Given this list of marker genes Atp8b4, Slc35d3, Vmp1, Atp11c, Slc25a24, Slc25a47, Atp10b, Vapa, Abcc6, Calhm4, Slc35a5, Slc35a3, Slc35a2, Prelid1, Xkr4, Apoa5, Calhm6, Pitpnb, Lrrc8b, Slc33a1, Lrrc8d, Slc17a9, Slc35c1 (solute carrier family 35, member C1), Serinc3, Etnppl, Ldlr, Slc66a2, Triap1, Slc35d2, Prelid3a (PRELI domain containing 3A), Dbi, Plscr1l1, Atp9b, Cd47, Atp8b1, Apoc1, Xkr6, Slc25a33, G6pc3, Tmem41b, Ano9, Osbpl5, G6pc1, Abcd1, Tmem30b, Plscr5, Pla2g10, Xkr8, Ano4, Ano7, Slc25a32, Slc25a51, Gjb1, Trpc5, Atp9a, Kcnn4, Slc19a1, Gja1, Abca3, Tmem30c, Slc35b4, Prelid2, Slc25a23, Prelid3b, Atp10a, Apoe, Apoc2l, Apoc3, Slc25a42, Xrcc4, Pitpnm3, Abcc5, Slc35c2, Atp11a, P2rx7, Abca12, Atp10d, Prap1, Plscr4 (phospholipid scramblase 4), Atp11b, Fasl, Apoa1, Esyt1, Serinc5, Adcy10, Spns1, Slc35b1, Atp8a2, Slc25a54, Abcb4, Slc37a1, Bltp1, Slc46a2, Vdac2, Slc44a4, Pitpna, Xkr7, Abcg8, Lrrc8c (leucine rich repeat containing 8 family, member C), Slc35b3, Xkr9, Slc25a41, Calhm5, Shoc2, Abcb1a, Calhm2, Slc25a19, Ank, Slc25a16, Atg9b, Slc25a25, Slc25a36, Mttp, Pitpnm1, Apoc2, Ano3, Clptm1l, Serinc2, Abcc4, Atp8b2, Slc25a4, Calhm1, Slc25a5, Scp2 (sterol carrier protein 2, liver), Pctp, Osbpl2, Scarb2, Epg5, Pitpnm2, Calhm3, Abca1, Slc37a2, Plscr1, Panx1, Plscr3, Lrrc8a, Tmem241, Lrrc8e, Slc37a4 (solute carrier family 37 (glucose-6-phosphate transporter), member 4), Abca7, Abcb1b, Slc35a1, Slc35b2, Tmem30a, Atp8b5, Apoa2, Pitpnc1, Mfsd2a (NCBI Gene Id 76574), Abca4, C2cd2l, Osbp, Slc35d1, Scarb1, Pltp, Tnfaip8l3, Atp8b3, Apoa4, Cptp, Atg9a, Slc25a17, Slc25a31, Plscr2, Atp8a1, Ano6, Abcg1, Slc4a1, Osbpl8, Abcc1, here is a description of the gene set: The directed movement of organophosphate esters into, out of or within a cell, or between cells, by means of some agent such as a transporter or pore. Organophosphate esters are small organic molecules containing phosphate ester bonds. Mouse Gene Set: GOBP_ORGANOPHOSPHATE_ESTER_TRANSPORT species: Mus musculus